The following is a description of a gene set: Any process that results in a change in state or activity of a cell (in terms of movement, secretion, enzyme production, gene expression, etc.) as a result of a vitamin stimulus. studied in species Homo sapiens Human Gene Set: GOBP_CELLULAR_RESPONSE_TO_VITAMIN, and this is the list of marker genes: TNC, GDAP1, PIM1, NCOA3, SNAI2, PHEX, FGF23, FES, MN1, SNW1, LEP, FOLR2, GPRIN3, PENK, CYP27B1, SFRP1, KANK2, BGLAP (bone gamma-carboxyglutamate protein), MIR125B1, MDM2, GAS6, FOLR1, POSTN, RXRA, TRIM24, COL1A1, CASR, MED1, VDR, CYP24A1, RXRB